Given this list of marker genes Bak1, Tyro3, Esr2, Axl, Esr1 (estrogen receptor 1 (alpha)), Bax, Wnt5a, Mertk, Lhx1, Rbp4, Lrp2, here is a description of the gene set: The reproductive developmental process whose specific outcome is the progression of the vagina over time, from its formation to the mature structure. Mouse Gene Set: GOBP_VAGINA_DEVELOPMENT species: Mus musculus